Given this list of marker genes Cntn2, Robo2, Fezf2, Atg7, Rac3, Sox1, Foxg1, Plxna3, Disc1, Slit2, Sall3, Atp7a, Rac1, Fgfr2, Ogdh, Nrp2, Wnt5a, Sema3a, Slc4a10, Zmiz1, Robo1, Nhlh2, Scyl2, Lhx6, Dclk2, Drd2, Fgfr1, Dcx, Arx, Gbx2 (NCBI Gene Id 320729), Gnaq, Rapgef2, Uqcrq, Secisbp2, Sema3e, Atf5, Fgf8, Plxna1, Ubb, Ndnf, Tfap2a, Lhx8, Nrp1, Drd1, here is a description of the gene set: The process whose specific outcome is the progression of a neuron that resides in the forebrain, from its initial commitment to its fate, to the fully functional differentiated cell. species: Mus musculus Mouse Gene Set: GOBP_FOREBRAIN_NEURON_DEVELOPMENT